The following is a description of a gene set: studied in species Homo sapiens Human Gene Set: GOBP_RIBOSOMAL_SMALL_SUBUNIT_ASSEMBLY The aggregation, arrangement and bonding together of constituent RNAs and proteins to form the small ribosomal subunit., and this is the list of marker genes: RPSA, RRP7A (NCBI Gene Id 27341), RPS28, MRPS7, METTL17, RRP7BP, ERAL1, RCC1L, RPS15, RPS27, RPS14, PWP2, RPSA2, MCAT, FAU, RPS5, RPS6, RPS19, XRCC5, RPS27L, PRKDC, ABT1